The following is a description of a gene set: Psoriasiform lesion studied in species Homo sapiens A skin lesions that resembles the lesions observed in psoriasis, viz., an erythematous plaque covered by fine silvery scales. Psoriasiform lesions can be observed in psoriasis as well as in other conditions including allergic contact dermatitis, seborrhoeic dermatitis, Atopic dermatitis, pityriasis rubra, and lichen simplex chronicus. Human Gene Set: HP_PSORIASIFORM_LESION, and this is the list of marker genes: CARMIL2, LRBA, RIGI, LDHA, IL7R